The following is a description of a gene set: species: Homo sapiens Genes down-regulated in DLD-1 cells (colon cancer) in response to hypoxia; might not be direct targets of HIF1A. Human Gene Set: MIZUKAMI_HYPOXIA_DN Hypoxia inducible factor-1 (HIF-1) is considered a crucial mediator of the cellular response to hypoxia through its regulation of genes that control angiogenesis. It represents an attractive therapeutic target in colon cancer, one of the few tumor types that shows a clinical response to antiangiogenic therapy. But it is unclear whether inhibition of HIF-1 alone is sufficient to block tumor angiogenesis. In HIF-1alpha knockdown DLD-1 colon cancer cells (DLD-1(HIF-kd)), the hypoxic induction of vascular endothelial growth factor (VEGF) was only partially blocked. Xenografts remained highly vascularized with microvessel densities identical to DLD-1 tumors that had wild-type HIF-1alpha (DLD-1(HIF-wt)). In addition to the preserved expression of VEGF, the proangiogenic cytokine interleukin (IL)-8 was induced by hypoxia in DLD-1(HIF-kd) but not DLD-1(HIF-wt) cells. This induction was mediated by the production of hydrogen peroxide and subsequent activation of NF-kappaB. Furthermore, the KRAS oncogene, which is commonly mutated in colon cancer, enhanced the hypoxic induction of IL-8. A neutralizing antibody to IL-8 substantially inhibited angiogenesis and tumor growth in DLD-1(HIF-kd) but not DLD-1(HIF-wt) xenografts, verifying the functional significance of this IL-8 response. Thus, compensatory pathways can be activated to preserve the tumor angiogenic response, and strategies that inhibit HIF-1alpha may be most effective when IL-8 is simultaneously targeted. from publication Mizukami Y, Jo WS, Duerr EM, Gala M, Li J, Zhang X, Zimmer MA, Iliopoulos O, Zukerberg LR, Kohgo Y, Lynch MP, Rueda BR, Chung DC (PMID 16127434), and this is the list of marker genes: FGF2, ANGPT1, PDGFB, CXCL8, LRP1, CXCR1